The following is a description of a gene set: from publication Chen Y, Wang X (PMID 31504780) Genes predicted to be targets of miRBase v22 microRNA hsa-miR-589-3p in miRDB v6.0 with MirTarget v4 prediction scores > 80 (high confidence targets). Human Gene Set: MIR589_3P species: Homo sapiens, and this is the list of marker genes: NAP1L2, NCOA5, SNIP1 (NCBI Gene Id 79753), KIAA0232, GDF6, TLCD4, RLIG1, MAPK9, ISCU, MGAT4A, DNAAF10, TRERF1, KRT6B, CLCN3, PFKFB3, BNIP3, EHMT1, SRD5A1, UEVLD, SERP1, BNC2, GOLGA8H, DNAJB14, MCC (MCC regulator of WNT signaling pathway), VCL, ZFP90, NLGN1, RSPH4A, PPP1R12B, FRMD4B (NCBI Gene Id 23150), CNOT4, DPAGT1, RASAL2, HASPIN, ZMYM2, SPRED1, FOS, RSRC2, RAPH1, APBA1, KMT2C, SLC44A1, SH2D1A, ZNF322, VTI1A, KRTAP24-1, UBR5, FABP4, SLC6A13, SPIN1, NEDD1 (NEDD1 gamma-tubulin ring complex targeting factor), RNF114, FKBP3, RIMS4, RAB18, PHKB, CDC37L1, RAD9B, IQGAP2, SRSF7, TMCC1, STK25, HROB, PIAS2, DNAH7, PPARGC1A, MYSM1, CHIC1, RDX, GOLGA8N, CAV2 (caveolin 2), ZMYM3, NAMPT, UNC5C, LRRC47, CIR1, DLX1 (NCBI Gene Id 1745), GOLGA8A, NRG3, PLEKHH1, FGF9, SLF1, RBFOX1, ZFYVE16, SLC22A23, PCDH7, SMG1, STARD3NL, ITPRIPL2 (NCBI Gene Id 162073), GOLGA8R, ADAMTSL1, PPP1R12A, NUS1, TSPYL6, GOLGA8Q, CBLB, COBLL1, GOLGA8T, ACYP2, JRKL, ECHDC1, HOXB8, TRIM22, PTPRT, TBCEL, DCAF7, TSFM, PGR, MAP1B, PARD3, TOP1, OLA1, SOD2, ZDHHC3, XIRP2, POU2F1, CPEB3, EZR, GPATCH2L, RNF145, RBM38, DOT1L, RBM27, SUB1, GOLGA8B, KNSTRN, ALDH1L2, PGAP1, BEND4, TDRD9, PDYN, PROX1, ABHD2, ANTXR2, RBM25, PCDH9 (NCBI Gene Id 57123), GRM1 (glutamate metabotropic receptor 1), ULBP2, TSPYL5, CAMK2B, IGF2BP2, LIN54, TMEM178B, VSIG4, RUNDC3B, NSRP1, TPD52, EIF2S3, TMEM109, MIER3, ZNF548, FNIP1, ANP32A, VAV3, DDHD2, E2F6, GBE1, TMEM60, DCAF6, RNF169, SLC2A2, ZNF704, JUND, HUWE1, MICU3, GOLGA8J, TRIP11, PATJ, PLA2G5, NFAT5, LNX2, MCM6, GABRA5, GAGE1, PPP6R2, TBC1D9, CREBL2, TTLL4, RPS6KA6, VASH2, MAGI1 (membrane associated guanylate kinase, WW and PDZ domain containing 1), KIRREL2, NF1, SMIM19, EPB41L4B, ADAMTS2, ST3GAL2, RBM19, TUBA1C, ADNP, SIPA1L2, HOOK3, NKAP, CTNNB1, STMN1, CHST2, ZCCHC14, KCNIP1, CD81, SPRING1, GJC1, TMEM196, SMAD4, TMEM121B, RCBTB2, PYGO1, CLOCK, UNK, PNMA2, CDCA8, GPR176, RORA, LIX1, CD36, RABGAP1L, ARMCX3, SLC25A12 (NCBI Gene Id 8604), CDK6, FAM168A, TSPAN3, ENPP2, APLNR, TPBG, CDC123 (cell division cycle 123), E2F7, DOK5, IFT81, RC3H1, MET, HSP90AB1, GOLGA8M, SYT4, ZCCHC3, KCNS3, ZFX, PAQR5 (NCBI Gene Id 54852), CEP72, CTTNBP2NL, SHISA9 (shisa family member 9), NAA30, ZBTB34, AVL9, ZNF652, SMYD2, MTX3, SLC35A2, RNF111, PTPRJ, KHSRP (NCBI Gene Id 8570), RNF125, SMU1, SORCS1, NPAT, PRICKLE2, HIF1A, GNPDA1